The following is a description of a gene set: In this study, an extensive analysis was conducted to define meta-programs (MPs) capturing intra-tumor heterogeneity across a spectrum of tumor types. The approach utilized non-negative matrix factorization (NMF) to analyze each cell type separately within individual tumor samples. This involved the analysis of malignant cells, macrophages, fibroblasts, endothelial cells, epithelial cells, T-cells, and B-cells. NMF was executed with varying parameter values (K=4, 5, 6, 7, 8, 9), thereby generating 39 programs for each cell type per sample. Each NMF program was summarized by the top genes based on NMF coefficients.\nRobust MPs were then delineated for each cell type using a set of stringent criteria, including recurrence within the same tumor, similarity to programs in other tumors, and non-redundancy within a tumor. Subsequently, these robust NMF programs were clustered (per cell type) based on Jaccard similarity, leading to the identification of MPs associated with each cell type.\nTo enhance the quality of the MPs, a refinement steps were undertaken, involving the removal of MPs suspected of reflecting low-quality data (with an overrepresentation of ribosomal proteins or mitochondrial-encoded genes), single-study inclusion, or similarity to miss-annotated cell types. Genes upregulated in subsets of cells of a given type within various tumors studied in species Homo sapiens Human Gene Set: GAVISH_3CA_METAPROGRAM_FIBROBLASTS_CAF_1 from publication Gavish A, Tyler M, Greenwald AC, Hoefflin R, Simkin D, Tschernichovsky R, Galili Darnell N, Somech E, Barbolin C, Antman T, Kovarsky D, Barrett T, Gonzalez Castro LN, Halder D, Chanoch-Myers R, Laffy J, Mints M, Wider A, Tal R, Spitzer A, Hara T, Raitses-Gurevich M, Stossel C, Golan T, Tirosh A, Suvà ML, Puram SV, Tirosh I (PMID 37258682), and this is the list of marker genes: FN1, COL10A1, MMP2, SPARC, SDC1 (syndecan 1), IGFBP3, ASPN, INHBA, ITGBL1, COL12A1, VCAN, COL1A2, COL1A1, COL5A1, SFRP2, ISLR, MMP11, CXCL14, DCN, TIMP3, FNDC1, DPT, PLAU, SFRP4 (secreted frizzled related protein 4), FBLN1, ACTA2, POSTN, MXRA5, COL6A3, TAGLN, ELN, SULF1, COL5A2, CTHRC1, THBS2, COL8A1, CCN2, PRSS23, COL11A1, MFAP5, CTSK, FBN1, PALLD (NCBI Gene Id 51653), LUM, IGFBP5, CCDC80, COL3A1 (collagen type III alpha 1 chain), COMP, MFAP2, AEBP1